The following is a description of a gene set: Human Gene Set: GOBP_PHOTORECEPTOR_CELL_DEVELOPMENT studied in species Homo sapiens Development of a photoreceptor, a cell that responds to incident electromagnetic radiation, particularly visible light., and this is the list of marker genes: RPGRIP1L, THRB, TULP1, THY1, CDHR1, GNAT1, FAM151B, CFAP418, CEP290, IFT20, BBS1, PRKCI, ROM1, CNGB1, GNGT1, RAB37, DZANK1, CRB1, RPGR, RP1, RPGRIP1, PRDM1, IFT140, NRL, FSCN2, USH1C, AHI1, NPHP4, PRPH2, OLFM3, PCARE, SAMD7, GNAT2, CABP4, NR2E3, MFSD2A, PAX6, MFRP (membrane frizzled-related protein), RORB, MYO7A, NAGLU, HCN1, CRB2, TH, ARL3 (ADP ribosylation factor like GTPase 3), RP1L1, BBS4, RDH13, SAMD11 (sterile alpha motif domain containing 11), VEGFA, POC5, NTRK2, PDE6C, DIO3